The following is a description of a gene set: species: Mus musculus Mouse Gene Set: MIR_218_1_3P_MIR_496B from publication Chen Y, Wang X (PMID 31504780) Genes predicted to be targets of miRBase v22 microRNA mmu_miR_218_1_3p, mmu_miR_496b in miRDB v6.0 with MirTarget v4 prediction scores > 80 (high confidence targets)., and this is the list of marker genes: Tefm, Tnrc18, Or51e2, Pafah1b1, Rsrc2, Kcna10, Cand1, Wdr82, Rcor1, Arhgap42, Slit2, Mrfap1, Cert1, Socs1, Mettl25b, Vbp1, Timm23, Sh3pxd2a, Ankrd29, Sulf1, Frk, Ero1b, Slc37a2, Gpatch1, Arhgef6, Sfmbt2, Sash1, Dnajb9, Bex6, Rfx7, Acvr2a, Zfta, Ipcef1, Kifap3, Gabrb1, Tomm20, Tfrc, Ptpre, Epas1, Cul4b, Prkd3, Rims2, Mmd, Kras, Gja1, Itfg1, Calm2, Hace1, Hspa1b, Ttll7, Mettl8, Hecw2, Neurod6, Ywhag, Retreg1, Edn1, Tnrc6b, Umad1, Nxpe4, Aak1, Snx5, Oasl2, Csgalnact2, Foxn2, Hs3st5, Krtap4-16, Dock9, Cpd, Vhl, Slc15a5, Sh3pxd2b, Tacc1 (NCBI Gene Id 78791), Nup153, Epha6, Slc6a3, Zfp518a, Ubn2, Camta1, Lum, Asb3 (NCBI Gene Id 78768), Cks1b, Cep57, Smndc1, Retreg3, Rag1, Acsl4, Pitx2, Ap1s2, Mbnl1, Mag, Rab35 (NCBI Gene Id 77407, RAB35, member RAS oncogene family)